The following is a description of a gene set: Human Gene Set: GSE26495_NAIVE_VS_PD1LOW_CD8_TCELL_DN T cell dysfunction is an important feature of many chronic viral infections. In particular, it was shown that PD-1 regulates T cell dysfunction during chronic LCMV infection in mice and PD-1 high cells exhibit an intense exhausted gene signature. These findings were extended to human chronic infections such as HIV, HCV and HBV. However, it is not known if PD-1 high cells of healthy humans have the traits of exhausted cells. In this study, we provide a comprehensive description of phenotype, function and gene expression profiles of PD-1 high versus PD-1 low CD8 T cells in the peripheral blood of healthy human adults as following: 1) The percentage of naive and memory CD8 T cells varied widely in the peripheral blood cells of healthy humans and PD-1 was expressed by the memory CD8 T cells. 2) PD-1 high CD8 T cells in healthy humans did not significantly correlated with the PD-1 high exhausted gene signature of HIV specific human CD8 T cells or chronic LCMV specific CD8 T cells from mice. 3) PD-1 expression did not directly affect the ability of CD8 T cells to secrete cytokines in healthy adults. 4) PD-1 was expressed by the effector memory (TEM) compared to ‘terminally differentiated effector’ (TEMRA) CD8 T cells. 5) Finally, an interesting inverse relationship between CD45RA and PD-1 expression was observed. from publication Duraiswamy J, Ibegbu CC, Masopust D, Miller JD, Araki K, Doho GH, Tata P, Gupta S, Zilliox MJ, Nakaya HI, Pulendran B, Haining WN, Freeman GJ, Ahmed R (PMID 21383243) studied in species Homo sapiens Genes down-regulated in comparison of naive CD8 T cells versus PD-1 low CD8 T cells., and this is the list of marker genes: RASSF1, SEMA4C, HOPX, PSEN2, RABGAP1L, SLFN11, RGS3, PDE4A, JAKMIP1, KATNAL1, MAP4 (NCBI Gene Id 4134), RHBDF2, MCOLN2, TOX, SAP30, SRGN, CAPN2, EIF4G3, ABHD15, AGPAT4, KAT2B, MICB, TARP, CD226, ANXA4, STARD3NL, BHLHE40, PPP4R1, C1orf216, SP140, SYTL2, RHOU, LPP, AUTS2, PITPNA, CD99 (CD99 molecule (Xg blood group)), TPRG1, LINC02481, PPP2R2B, DPY19L1, SESN2, MXRA7, SLC15A4, SLAMF7, RAP2B, GBP5, TBX21, DOK2, TTC38, TTYH2, FAS, TP53INP1, CD58, JAKMIP2, CHN2, ACOT9, SMAD3, AGO4, OPTN, ZEB2 (zinc finger E-box binding homeobox 2), PLAAT3, SPATS2L (spermatogenesis associated serine rich 2 like), BTD (NCBI Gene Id 92108), DIAPH2, SH3BP5, SANBR, GZMH, PLEKHO2, PREX1, RAB27A, RALGDS, TIGIT, MCTP2, GYG1, SYT11, TSPAN2, GNLY (NCBI Gene Id 7843), JAZF1, AHNAK, STOM, CNNM4, PTP4A2, GZMB, PRR5L, CAST, PTGDR, SRXN1 (NCBI Gene Id 140809), SNTB2, WWP2, TCIRG1, LPCAT1, LGALS1, ZDHHC14, MYO6, CXXC5, LAG3, PAM, TMED9, B4GALT5, MATK, DENND3, ADCY9, GAB3, C12orf75, ARHGAP35, TOGARAM2, SLCO3A1, CCR5, YPEL1, GAK, PRSS23, CCL5, TGFBR3, PIK3AP1, MAP3K8, PTPN4, PRF1, PIEZO1, TNFRSF1B, CCL4, RASGEF1A, STK40, ADAM8, RAP1GAP2, PIK3R3, MIAT, PIK3R5, NCALD, ANXA2P2, GFOD1, NINJ2, SLC35G2, ATP2B4, NKG7, APOBEC3G, ADRB2, FCRL3, CHST11, SFXN3, PDIA6, IL2RB, TMEM273, TOR2A, YWHAQ, MYBL1, DGKQ, CLEC2B, ITGB1, APMAP, ASCL2, OSBPL5, WIPI1, EFHD2 (NCBI Gene Id 79453), ITGAL, FGFBP2, SNX5, SYNE2, TTC22, ACTN4 (NCBI Gene Id 81), PYHIN1, RAB40B (RAB40B, member RAS oncogene family), ELF4, S100A4, SLC27A3, CTDSP1, IL10RA, SYTL3, MAF, ADGRG5, ADAP1, EOMES, GZMA, ATXN1, PRNP, MAN1A1, PPM1A, VANGL1, FYN, SMAD7, GPR68, DNAJC1, ADGRG1, CTSC, SLC66A3, NPC1, SUSD1, WSB2, MBP, CHST12, MICAL2, PDGFD, KLRG1, ANXA2 (annexin A2), TNFSF12, SLAMF6, CST7, KLRD1, NIBAN1, TMEM184B, CD244